Given this list of marker genes ESYT3, SMG7, ELAVL4, PRDM4, ACVR2B, OTUD7B, HDAC9, USB1, MACO1, DLGAP4, HLA-DRA, ANO6, GPATCH2 (G-patch domain containing 2), ZBTB20, SCUBE3, METTL13, RNF212, SNX25, CAP1, RNLS, TSPAN6, IRF9, INO80D, RC3H1, SEC22B, ANK2, ATE1, TDRD1, RAB31, ALDH5A1, WDR19, CREB3L2, KPNA3, TMEM178B, SKA2, HERC3, C11orf87, KRT40, RARB, DLG2, MTMR10, RNF168, CRADD, CEP135, ATP8A1, GALR1, TLL2, KPNA1, F9, UNC5C, ATF7IP, ERCC4, DEPDC4, GDPD1, AGL, STK39, WDR36, MMACHC, ZNF550, C1orf198, IMPACT (impact RWD domain protein), SLC16A2, SLC19A3, MYADM, TMEM19, AMER1, FNDC5, CTNNA1, SEC63, ESRP1, TRIM8, ELFN1, HINFP, TRA2A, TOR1AIP1, AR, KIF3A, ITCH, AP3M2, ARID4A, KRAS, TCP1 (NCBI Gene Id 6950), STYK1 (NCBI Gene Id 55359), ZFP36L2, POGK, ALDH1A3, GLDC, PDCL3, FBXO45, C4orf33, EGLN3, ERCC1, EPS15, CD302, LY75-CD302, NAV3, KLHL31, POLQ, ZNF264, HNRNPR, STAMBP, FAM98B, ZDHHC3, MN1, GCFC2, KIF5B, CCNT1, MED24, HELQ, LRRC27, OSBPL6, PANK3, ARMCX1, DOCK5, CBLN4, PPM1A, PLEKHB1, NRCAM, RABL3, FAM120B, STK35, ZFYVE26, CTTNBP2 (cortactin binding protein 2), CAMK1D, TSR2, GTF2A1, RBBP4, CEP350, RBM20, BAZ1A, XBP1, EXOC6B (exocyst complex component 6B), MAN1C1, TMEM126B, LCE2B, TEAD1, TTC14, ITM2B, CLDND1, XPO7, CDH12, FGF9, CYRIB, ITGB8, RASAL2, DEFB132, SUFU, BTF3L4, GATA4, SPTLC3, MIER3, AGO1, ARHGEF35, AP1AR, SC5D, NUP98 (NCBI Gene Id 51457), GANAB, RAB18, SLC26A1, SPATS2, RALA (NCBI Gene Id 5898), BTD, HAUS6, USP49, ZBTB41, CBX3, LMBRD2, RNF212B, ZFP36L1, GNAQ, OGA, PM20D2, STXBP5, TPRG1, NCOA5, LMAN1, HOXB2, TP53INP2, OR2L13, PDE1C, MLF2, CDIN1, CNR1, HNRNPK, PI15, DDX17, PRDM1, HDGFL3, SDC1, KTI12, KLF8, C17orf67, SUSD1, ASTN1, GFRAL, VPS37A, TRIAP1, KRIT1, NMNAT2, DDX52, ZNF609, LMBRD1, CSNK1G3, VWA5A, TMOD2, HIF3A, DDO, RCBTB2, ARL3 (NCBI Gene Id 403), DYRK1A, GPLD1, CFL1, ANKRD45, BUB3, TBCA, FSD1L, DCX, KATNIP, SETD4, here is a description of the gene set: Genes predicted to be targets of miRBase v22 microRNA hsa-miR-3916 in miRDB v6.0 with MirTarget v4 prediction scores > 80 (high confidence targets). studied in species Homo sapiens Human Gene Set: MIR3916 from publication Chen Y, Wang X (PMID 31504780)